The following is a description of a gene set: species: Homo sapiens The directed movement of L-alpha-amino acid across a membrane by means of some agent such as a transporter or a pore. Human Gene Set: GOBP_L_ALPHA_AMINO_ACID_TRANSMEMBRANE_TRANSPORT, and this is the list of marker genes: SLC7A5P2, SLC7A5 (NCBI Gene Id 8140), SLC25A18, SLC17A6, SLC17A7, SLC17A8, SLC7A9, TNF, SLC38A2, KCNJ10, SLC11A1, SLC1A7, SLC38A10, SLC25A22, SLC1A6, SLC7A10, SLC66A1, SLC1A1, SEPTIN2, NTSR1, SLC1A3, SLC1A2, SLC7A3, SLC25A15, SLC38A9, SLC25A2, ITGB1, SLC7A11, PER2, SLC25A29, SLC15A4, ARL6IP1, SLC7A2, SLC38A1, SLC36A4, PSEN1, SLC1A5, TTYH2, EPM2A, CTNS, SLC47A1, ATP1A2, SLC25A13 (NCBI Gene Id 10165), UCP2, SLC6A20, SLC38A5, SLC7A5P1, SLC22A2, CLN3, SLC7A13, ARL6IP5, SLC38A11, SLC7A1, SLC25A12, SLC7A7, SLC38A6, TTYH1, SLC3A1, SLC66A1LP, SLC43A1, CLTRN, SLC3A2, SLC38A4, ACE2, SLC38A3, SLC25A26, GRM1, SLC1A4, SLC7A8, CLN8, SLC38A8 (NCBI Gene Id 648732), SLC7A6, SLC43A2, TTYH3 (NCBI Gene Id 80727), PRAF2